The following is a description of a gene set: The gene expression program underlying the specification of human cell types is of fundamental interest. The study authors generated human cell atlases of gene expression and chromatin accessibility in fetal tissues. For gene expression, the study authors applied three-level combinatorial indexing to >110 samples representing 15 organs, ultimately profiling ~4 million single cells. The study authors leveraged the literature and other atlases to identify and annotate hundreds of cell types and subtypes, both within and across tissues. Our analyses focused on organ-specific specializations of broadly distributed cell types (such as blood, endothelial, and epithelial), sites of fetal erythropoiesis (which notably included the adrenal gland), and integration with mouse developmental atlases (such as conserved specification of blood cells). These data represent a rich resource for the exploration of in vivo human gene expression in diverse tissues and cell types. Human Gene Set: DESCARTES_MAIN_FETAL_LENS_FIBRE_CELLS from publication Cao J, O'Day DR, Pliner HA, Kingsley PD, Deng M, Daza RM, Zager MA, Aldinger KA, Blecher-Gonen R, Zhang F, Spielmann M, Palis J, Doherty D, Steemers FJ, Glass IA, Trapnell C, Shendure J (PMID 33184181) studied in species Homo sapiens Marker genes curated from the annotated cluster as represented in the Descartes Human Gene Expression During Development database., and this is the list of marker genes: LRSAM1 (leucine rich repeat and sterile alpha motif containing 1), HMGB1P29, TPO, H2BC18, NLRP13, ADAM17, LSAMP-AS1, SNX1 (sorting nexin 1), ALG5, LCMT1-AS1, RPS3AP38, RNF25, CYLD-AS2, RPL23AP32, TMPRSS5, FN3KRP, GACAT3, LY6G5B, HMGB1, SRP54-AS1, PARM1-AS1, ZNF761, C12orf42, RPL23AP7, RN7SL378P, PRX, CHUK, UBR4, NHS, BASP1-AS1, LINC00903, SEC14L1P1, HERC4, HLCS-AS1, LINC02177, DBIL5P2, TRPM8, LINC02720, RSPO4, KXD1-AS1, CRYGEP, TRIB1AL, PALM2AKAP2, CAPRIN2, ERVK9-11, PCNX4-DT, P3H2-AS1, ENSG00000258657, LENEP, NXPE2, SLC24A2, LPIN1, LINC01885, RNU6-147P, C12orf60, ENSG00000261118, RN7SL36P, TUSC7, TMEM42, NFE2L1-DT, TEX11, LINC00158, DYNC1I1 (dynein cytoplasmic 1 intermediate chain 1), CRYGD, CRYGS, MIR624, LGSN, DOCK6-AS1, ENSG00000251143, LINC02413, RN7SL12P, CRYBA2, TGM6, DEPDC1P1, VIT, DST-AS1, CRYBB2 (NCBI Gene Id 879), BPIFB4, BTBD10P2, SMCO2, GPR137B, ARHGEF37, CTIF, MINDY2-DT, RNU4-38P, FLYWCH1, TGFB2-AS1, HSPA6, PTPRU, NMRK1, LCTL, CRMA, CLRN1, KNOP1, AURKC, NXF5, LINC02596, GUCY2GP, TMLHE, LINC01950, LMCD1-AS1, CAMK2A, CCDC169, FDXACB1 (NCBI Gene Id 91893), TEX14BP (NCBI Gene Id 651048), LIPI, MBOAT1, LINC02024, CHRNA2, GJA8, ARID3B, TSSC2, RNU5E-8P (NCBI Gene Id 100873837), WNT7A, STAMBPL1, UCHL1-DT, PRANCR, ME1, RNF175, LINC02220 (NCBI Gene Id 105374658), LINC01170, EPB41L4A, SIPA1L3, SERPINB6, CYB5R4 (cytochrome b5 reductase 4), DNMBP-AS1, CTBP1-DT, MEGF9, EPS15L1 (epidermal growth factor receptor pathway substrate 15 like 1), LINC02028, LINC01440, NBEAP1, HSF4, CAST, BFSP1, LINC01789, ST6GAL2-IT1, IGSF22-AS1, CAHM (NCBI Gene Id 100526820), DICER1-AS1, ENSG00000214803, PELI1, LINC02624, SGSM3-AS1, LINC02141 (long intergenic non-protein coding RNA 2141), BCO2, ENSG00000229770, SORD, H2AZ2P1, GJA3, TDRD7, LINC01166, TMEM117, OXA1L-DT, MYO18A, LINC01389, FAM209B, NOL3, BIRC7, MIP, BEND3P1, CPSF4L, PROX1-AS1, DNMBP, E2F5-DT, LINC00901, FHIT, SQOR, SIPA1L1, GARIN1B, RNU6-1111P, RPL17P13, ZFYVE21, SEC61G-DT, COL4A6, ZNF778-DT, NHLRC1, EFCAB8, ERICH5, BTF3-DT, NAV2-AS1, GRPEL2-AS1, CPEB1, DRG1P2, TMEM114, RBM22P2, ARSI, TDH, DCTN5, ARGLU1, RASGRF1, TIGD6 (tigger transposable element derived 6), SNORD55, TIMELESS, LINC02763, CLIC5, CRYAB, RAB39A, CRYGA, MIR31HG, CMTM7 (NCBI Gene Id 112616), STRCP1, LNPK, SLC25A44, LINC00471, ZBED5-AS1, SPTBN5, ENSG00000232732, HSPA5-DT, CCDC159, GPR89B, ENSG00000234210, CRYBA4, TEX35, ENSG00000223786, P3H2, FAAHP1, LINC00519, CARHSP1, CARD14, TPM3P9, KCNMB2-AS1, ELOA-AS1, RNF139-DT, LDLRAD3, FBXO3, CRYGB, RNU6-880P, MALAT1, TLK2P2, IQSEC1, NRCAM, CRYBB3, LINC02367, RNU4-40P, ENSG00000227463 (novel transcript), TENM3-AS1, LINC01429 (long intergenic non-protein coding RNA 1429), FBXO34, NREP-AS1, NPLOC4, TBC1D22A-DT, PIP5KL1, CRYBA1, CERK (ceramide kinase), LRRC39, ANK2-AS1, SOX1-OT, SOHLH2, FABP5, RPL23P2, BHMT, INPP5F, FAM222A-AS1, MIPOL1 (mirror-image polydactyly 1), SUCO, BMAL2, HMSD, USPL1, KDM3A, LIM2, LINC01339, MSLNL, ENSG00000235834, HDAC6, STPG4, LINC03060, GSS, MKRN10P, FAM182A, CRYGC, ZSCAN30, KIAA1217, ENSG00000243276, LYPD6, LINC00392, ZNF674-AS1, BFSP2, RPL7P49, LRRC42, PRDX6-AS1, PCDHAC2, UTS2B, TMEM167B-DT